The following is a description of a gene set: Treg species: Homo sapiens from publication He P, Lim K, Sun D, Pett JP, Jeng Q, Polanski K, Dong Z, Bolt L, Richardson L, Mamanova L, Dabrowska M, Wilbrey-Clark A, Madissoon E, Tuong ZK, Dann E, Suo C, Goh I, Yoshida M, Nikolić MZ, Janes SM, He X, Barker RA, Teichmann SA, Marioni JC, Meyer KB, Rawlins EL (PMID 36493756) Human Gene Set: HE_LIM_SUN_FETAL_LUNG_C4_TREG_CELL, and this is the list of marker genes: SESN3, SLAMF1, GK, PTMS, PERP, LGALS9, TRAF1, CHRM3-AS2, SIT1, TMEM154, CD5, RGPD2, TNFRSF4, HNRNPLL, IL2RA, CD79A, SNX9, CD28, RTKN2 (rhotekin 2), IKZF4, HS3ST3B1, DUSP4, NCF4, BCL2L11, CTLA4, FOXP3, PELI1, GPA33, EPHX2, CCR4, SIRPG, BIRC3, FBLN7, ICOS, TBC1D4, CD4, RGPD1 (NCBI Gene Id 400966), TSPAN5, CYTOR, FAS (Fas cell surface death receptor)